Given this list of marker genes PPARA, MIR30C1, FBLN1, MIR130A, MIR141, here is a description of the gene set: species: Homo sapiens A process in which a symbiont alters or subverts a biological process in its host organism. The host is defined as the larger of the organisms involved in a symbiotic interaction. Human Gene Set: GOBP_SYMBIONT_MEDIATED_PERTURBATION_OF_HOST_PROCESS